Given this list of marker genes Csk, Egf, Hras, Pxn, Areg (NCBI Gene Id 11839), Ubc, Ptpn3, Sos1, Eps15l1, Epgn, Sh3gl2, Fam83a, Sh3gl1, Fam83d, Pag1, Stam2, Ptpn12, Rps27a, Stam, Epn1, Sh3gl3, Lrig1, Gab1, Uba52rt (NCBI Gene Id 676687), Cbl, Ptpn11, Spry2, Src, Plcg1, Tgfa, Egfr, Uba52, Shc1, Pik3ca, Cdc42, Arhgef7, Ereg, Sh3kbp1, Btc, Aamp, Grb2, Eps15, Hgs, Ptprk, Ubb, Hbegf, Pik3r1, Fam83b, Spry1, Kras, here is a description of the gene set: studied in species Mus musculus Signaling by EGFR Mouse Gene Set: REACTOME_SIGNALING_BY_EGFR